Given this list of marker genes UMOD, SLC17A1, SLC17A2, SLC17A4, SLC22A12, ABCC4, SLC2A9, SLC22A13, ABCG2, SLC17A3, SLC23A1, here is a description of the gene set: The directed movement of urate into, out of or within a cell, or between cells, by means of some agent such as a transporter or pore. Human Gene Set: GOBP_URATE_TRANSPORT studied in species Homo sapiens